The following is a description of a gene set: species: Mus musculus Mouse Gene Set: GOMF_DNA_REPLICATION_ORIGIN_BINDING Binding to a DNA replication origin, a unique DNA sequence of a replicon at which DNA replication is initiated and proceeds bidirectionally or unidirectionally., and this is the list of marker genes: Dhx9, Mcm5, Ddx11, Cdc6, Orc2, Pola1, Mcm10 (minichromosome maintenance 10 replication initiation factor), Orc1, Orc3 (origin recognition complex, subunit 3), Orc5, Mcm2, Cdc45, Grwd1, Orc4, Kat7